The following is a description of a gene set: species: Homo sapiens Human Gene Set: GOBP_LUNG_ASSOCIATED_MESENCHYME_DEVELOPMENT The biological process whose specific outcome is the progression of a lung-associated mesenchyme from an initial condition to its mature state. This process begins with the formation of lung-associated mesenchyme and ends with the mature structure. Lung-associated mesenchyme is the tissue made up of loosely connected mesenchymal cells in the lung., and this is the list of marker genes: CTNNB1, HOXA5, FGF9, PTK7, FGFR1, FGFR2, DPPA4, WNT11, SHH